Given this list of marker genes Htt, Trem2, Sco1 (NCBI Gene Id 67104), Egln1, Zmpste24 (zinc metallopeptidase, STE24), Kcnj8, Igtp, Irgm2, Lrrk2, Kcnj11, Prkaa1 (NCBI Gene Id 105952), Camkk2, Myh7b (myosin, heavy chain 7B, cardiac muscle, beta), Cp (NCBI Gene Id 51906), Irgm1, Pcp4 (NCBI Gene Id 18546), here is a description of the gene set: studied in species Mus musculus Mouse Gene Set: GOBP_CAMKK_AMPK_SIGNALING_CASCADE The series of molecular signals in which calmodulin-dependent protein kinase activity enabled by a CAMKK directly activates an AMPK. The cascade begins with calmodulin binding calcium which in turn binds CAMKK enabling its calmodulin-dependent protein kinase activity. The cascade ends with AMP-activated protein kinase activity.